Given this list of marker genes Gng3, Arhgef6 (Rac/Cdc42 guanine nucleotide exchange factor 6), Gng4, Gng12, Gng13, Cdc42, Gng2, Gng11, Gnb2, Gnb4, Gng5, Pak1, Gnb1, Gngt2, Gng8, Gng10, Gnb3, Gng7, Gngt1, Gnb5, here is a description of the gene set: species: Mus musculus Mouse Gene Set: REACTOME_G_BETA_GAMMA_SIGNALLING_THROUGH_CDC42 G beta:gamma signalling through CDC42